The following is a description of a gene set: Mouse Gene Set: GOMF_ALCOHOL_BINDING Binding to an alcohol, any of a class of alkyl compounds containing a hydroxyl group. species: Mus musculus, and this is the list of marker genes: Anxa6, Vdac2, Osbpl3, Osbp2, Tmem97, Sidt1 (SID1 transmembrane family, member 1), Prom1, Trpc5 (NCBI Gene Id 22067), Osbpl6, Apod, Apoa1, Sult2b1, Dpm1, Slc38a9, Prom2 (prominin 2), Cyp11a1, Tpk1, Tspo2, Star, Adh4, C8g, Trpc7, Nfe2l1, Lrat, Stra6, Ninj2, Trpc6, Adh7, Scap, Vdac1, Adap1, Trpc1, Npc2, Itpr2, Gramd1b, Itpr1, Stard6, Gramd1a, Mtor, Erlin2, Adap2, Erlin1 (NCBI Gene Id 98152), Cdipt, Cd81, Ptch1, Stard4, Soat1, Stard3nl, Rbp2, Astn2, Soat2, Scarb2, Npc1 (NCBI Gene Id 98121), Stard5, Plcl2, Npc1l1, Syp, Crabp2, Trpc4, Crabp1, Rbp3 (NCBI Gene Id 218905), Osbpl8, Osbpl7, Snap91, Osbpl5, Crp, Prkce, Trpc2, Syt2, Trpc3, Osbpl1a, Osbpl2, Cyth2 (cytohesin 2), Minar2, Pmp2, Plcd1, Rbp4, Rbp7 (retinol binding protein 7, cellular), Scp2, Xpr1, Gpr155, Rph3a, Itpr3, Cyp2w1, Gramd1c, Apoa2, Osbpl10, Gle1, Rlbp1, Stard3, Rbp1